Given this list of marker genes NKX3-2, RIGI, AMOTL1, UNK, CCHCR1, TTC28, SKA2P1, PARP3, ASPA, FOXJ3, COQ9, PRKCB, CXCR3, NMT1, STEAP2, MYO1F, ORAI1, EHD3, KIF3A, SIDT1, MUCL3, NEFM (NCBI Gene Id 4741), SLC4A2, ARHGEF1, ILDR1, ABCC3, MRPS26, OSBP (NCBI Gene Id 5007), SOHLH1, STK11IP (NCBI Gene Id 114790), MORF4L1, MED29, NPSR1, IGDCC4 (NCBI Gene Id 57722), TFB2M, PPM1M, ELMO3, L1TD1, ELOA, NNMT, MOCS1, E2F2, UTP25, TSPAN3, PNPLA7 (patatin like phospholipase domain containing 7), EHD4, CLCN7, PRR5, SFPQ (splicing factor proline and glutamine rich), LARP1B, RNF19B, SEMA4B, RAF1, IRF9 (interferon regulatory factor 9), ACSBG2, RMND5B, MIIP, SLC22A15, ENTPD5, DGKD, UBL7, TCTN2, MSRB3, CITED2, PML, TINAG, GPR132, GRK6, TNFSF14, SLC8A3, TIGD4, SNX15, CALB2, SYT5, VIPR1, LMF1, CARMIL2, LENG1, FAM3C, STRIP1, BSND, NR2F2, PCDH8, CAP1, FIZ1, EMP1, ETV3, FKBP5, IGF2R, KDM5B, TMEM126B, ADAM17 (ADAM metallopeptidase domain 17), IL1RL1, RDH11, TBC1D14, CTCF, SLC28A2, NUDT14, AUP1, PAPOLA, ANXA11, ITGAM, DENND1A, AGK, PPP1R12C, PAK1, LHPP, SLC52A1, CAPN6, OSR1, MTMR4, ZMYND8, GARIN1B, NFKBIB, CXCL12, CPNE5, OTOP3, WHAMM, SSBP4, TPST2, SLC27A1, NSDHL, FBLN2, TBX20, PDE4DIP, ABHD16B, SENP2, BRMS1, SLAIN2, CSRP2, NHLRC3, KLC4, AKAP12, GLS2, STK36, DUSP5, SIK1, INO80, LAMC1, ECD, HNRNPUL1, SUFU, MPP1, FLI1, PLS1, PPM1D, ABLIM1, UNC45A, PSMF1, CCRL2, CPPED1, MORF4L2, POU5F1, HSD3B2, NCKAP1, GDI2, POLR1A, RIC8B, GPATCH4, CORO7, CDC25A, RBM38, PLOD3, TMC8, RFNG, POU6F1 (NCBI Gene Id 5463), LGALS3BP, SLC25A16, CERS6, here is a description of the gene set: Human Gene Set: GSE40274_SATB1_VS_FOXP3_AND_SATB1_TRANSDUCED_ACTIVATED_CD4_TCELL_UP from publication Fu W, Ergun A, Lu T, Hill JA, Haxhinasto S, Fassett MS, Gazit R, Adoro S, Glimcher L, Chan S, Kastner P, Rossi D, Collins JJ, Mathis D, Benoist C (PMID 22961053) The transcription factor FoxP3 partakes dominantly in the specification and function of FoxP3+ CD4+ T regulatory cells (Tregs), but is neither strictly necessary nor sufficient to determine the characteristic Treg transcriptional signature. Computational network inference and experimental testing assessed the contribution of several other transcription factors (TFs). Enforced expression of Helios or Xbp1 elicited specific signatures, but Eos, Irf4, Satb1, Lef1 and Gata1 elicited exactly the same outcome, synergizing with FoxP3 to activate most of the Treg signature, including key TFs, and enhancing FoxP3 occupancy at its genomic targets. Conversely, the Treg signature was robust to inactivation of any single cofactor. A redundant genetic switch thus locks-in the Treg phenotype, a model which accounts for several aspects of Treg physiology, differentiation and stability. studied in species Homo sapiens Genes up-regulated in CD4 T conv over-expressing SATB1 versus SATB1 and FOX3P.